Given this list of marker genes GTF2H1, CAVIN1, POLR1D, POLR2K, POLR1G, POLR2L, POLR2F, MNAT1, TBP, TTF1, GTF2H4, ERCC2, TAF1B, GTF2H5, GTF2H2, POLR1E, CCNH, POLR1F, POLR1H, TAF1D, POLR2E, TAF1C (NCBI Gene Id 9013), POLR1C, RNA45S5, GTF2H3 (general transcription factor IIH subunit 3), ERCC3, POLR2H, POLR1A, CDK7, 45S pre-rRNA gene, UBTF, POLR1B, TAF1A (TATA-box binding protein associated factor, RNA polymerase I subunit A), here is a description of the gene set: species: Homo sapiens Reactome Pathway: RNA Polymerase I Transcription Termination part of: RNA Polymerase I Transcription Termination of transcription by RNA polymerase I is a 4 step process. Initially TTF-1 binds the template rDNA. This complex pauses polymerase I allowing PTRF to interact with the quaternary complex releasing both pre-rRNA and Pol I from the template and TTF-1.